Given this list of marker genes SRSF1, EPHA2, TSC22D3, PLK2, NFKB2, RIGI, MMP15, IFIT1, RASL12, MFAP2, NR4A1, KRT14, SERPINB5, PDE2A, ELL2, RAB1A, CYTH1, KRT19, CCN1, H2BC12, JUNB, EGR3, SNAI2, IFIT2, ATF4, FUBP1, BCAR3, KLRC2, here is a description of the gene set: The infection of human cells by adenoviruses leads to a gradual reduction in the activity of host cell functions while viral gene expression progresses in a regulated way. We used the DNA microarray technique to determine the transcriptional activity profiles of cellular genes upon infection with adenovirus type 12 (Ad12). The microarray data were validated by quantitative real-time PCR for genes which showed significant alterations after Ad12 infection. At 12 h postinfection, there is a striking up-regulation between 10- and 30-fold in the expression of the G1P2, IFIT1, and IFIT2 cellular immune response genes compared to mock-infected cells. At later stages of infection, when the majority of regulated cellular genes has been turned down, a limited number of cellular genes exhibit increased activities by factors of 3 or less. These genes belong to the signal transduction or transcriptional regulator classes or are active in protein degradation, like ANPEP, an aminopeptidase. The SCD and CYP2S1 genes function in lipid metabolism. The eucaryotic translation initiation factor 4 is up-regulated, and one of the major histocompatibility complex genes is diminished in activity. For two of the genes, one up-regulated (CTSF gene) and one down-regulated (CYR61 gene), alterations in gene activity were confirmed at the protein level by Western blotting experiments. Increased genetic activity of cellular genes late in adenovirus infection has not been reported previously and demonstrates that Ad12 has a sustained control of host cell gene expression well into the late phase of infection. Human Gene Set: DORN_ADENOVIRUS_INFECTION_12HR_UP studied in species Homo sapiens Genes up-regulated in HeLa cells (cervical carcinoma) 12 h after infection with adenovirus Ad12. from publication Dorn A, Zhao H, Granberg F, Hösel M, Webb D, Svensson C, Pettersson U, Doerfler W (PMID 15681441)